Given this list of marker genes Plcg1, Ccdc88a, Irs2, Ptpn11, Pdpk1, Irs3, Irs4, Ptprf, App, Igf1, Slc2a2, Snx2, Snx1, Ptpn1, Shc1, Src, Igf2, Grb10, Pik3r1, Ins2, Irs1, Igf1r, Lmbrd1, Sorbs1, Snx4, Enpp1, Ins1, here is a description of the gene set: Mouse Gene Set: GOMF_INSULIN_RECEPTOR_BINDING studied in species Mus musculus Binding to an insulin receptor.